The following is a description of a gene set: electronically inferred by orthology from the curated human pathway studied in species Mus musculus This event has been computationally inferred from an event that has been demonstrated in another species.<p>The inference is based on the homology mapping from PANTHER. Briefly, reactions for which all involved PhysicalEntities (in input, output and catalyst) have a mapped orthologue/paralogue (for complexes at least 75% of components must have a mapping) are inferred to the other species. part of: Hedgehog ligand biogenesis Reactome Pathway: Release of Hh-Np from the secreting cell, and this is the list of marker genes: Shh, Ihh, Notum